The following is a description of a gene set: Disassembly of the destruction complex and recruitment of AXIN to the membrane Mouse Gene Set: REACTOME_DISASSEMBLY_OF_THE_DESTRUCTION_COMPLEX_AND_RECRUITMENT_OF_AXIN_TO_THE_MEMBRANE species: Mus musculus, and this is the list of marker genes: Ppp2r5d, Fzd1, Ppp2cb, Wnt8a, Fzd5, Frat1, Lrp6, Ppp2r5e, Gsk3b, Csnk1a1, Wnt3a, Fzd2, Amer1, Dvl1, Wnt8b, Ppp2r5a, Axin1, Ppp2r1b, Ppp2r5c, Dvl3, Ctnnb1, Ppp2r1a, Frat2, Wnt1, Ppp2ca, Apc, Lrp5, Cav1, Ppp2r5b, Dvl2 (dishevelled segment polarity protein 2)